The following is a description of a gene set: The cellular developmental process involved in cell fate commitment that occurs after cell fate specification, in which a cell is irreversibly committed to a cellular developmental fate which is heritable on cell division. Human Gene Set: GOBP_CELL_FATE_DETERMINATION studied in species Homo sapiens, and this is the list of marker genes: MEF2C, SOX17, FEZF2, TBX2, EBF2, HOXA2, ATOH1, FOXG1, GATA2, PTCH1, NOTCH2, TRIM15, CYP26B1, HES1, NOTCH4, MESP1, DLL1, MCL1, NKX2-2, WNT7A, WNT1, GATA3, PAX2, PTCH2, IFRD1, BMP4, ASCL1, POU5F1, PAX6, LBX1, BARHL2, GATA6, KLF4, CTNNB1, ISL1, TNXB, JAG1, PRRX1, MYOD1, CDC42, DSCAML1, NKX6-3, PROX1